The following is a description of a gene set: Mouse genes annotated to tumor regression (MP:0010537) retrieved from the Mouse Genome Informatics database via MouseMine from publication Motenko H, Neuhauser SB, O'Keefe M, Richardson JE (PMID 26092688) Mouse Gene Set: MP_TUMOR_REGRESSION species: Mus musculus, and this is the list of marker genes: Cav2, Trp53 (transformation related protein 53), Tnfrsf1a, Cdc20, Mir155, Id1, Stat1